The following is a description of a gene set: Genes changed by expression of activated form of HRas in MEF cells (embryonic fibroblast) with or without p65/c-Rel complex. from publication Hanson JL, Hawke NA, Kashatus D, Baldwin AS (PMID 15492243) Extensive data indicate that oncoproteins, such as oncogenic H-Ras, initiate signal transduction cascades that ultimately lead to the activation of specific transcription factors. We and others have previously demonstrated that Ras activates the inherent transcriptional activation function of the transcription factor nuclear factor kappaB (NF-kappaB). Supportive of the importance of NF-kappaB in transformation, Ras-induced cellular transformation can be suppressed by expression of IkappaBalpha, an inhibitor of NF-kappaB, or by dominant-negative forms of the upstream activator IkappaB kinase (IKK). However, conclusive evidence for a requirement for NF-kappaB subunits in oncogenic transformation has not been reported. Furthermore, there is little understanding of the gene targets controlled by NF-kappaB that might support oncogenic conversion. The data presented here demonstrate that, although both p65 and c-Rel enhance the frequency of Ras-induced cellular transformation, these NF-kappaB subunits are not essential for Ras to transform spontaneously immortalized murine fibroblasts. Microarray analysis identified a set of genes induced by Ras that is dependent on NF-kappaB for their expression and that likely play contributory roles in promoting Ras-induced oncogenic transformation. species: Mus musculus Mouse Gene Set: HANSON_HRAS_SIGNALING_VIA_NFKB, and this is the list of marker genes: Pkp1, Aldh1a3, Rnf19b, Pvr, Pip5k1a, Crisp1, Stk10, Lgals7, Cgref1, Klf3, Tslp, Sox5, Adra2c, Clcf1, Nppb, Serpinb2, Tmod2, Col18a1, Adra2a, Or4e1, Selplg, Gm13889, Oas1h, Sh3rf1